The following is a description of a gene set: Human Gene Set: GOBP_SIGNAL_COMPLEX_ASSEMBLY species: Homo sapiens The aggregation, arrangement and bonding together of a set of components to form a complex capable of relaying a signal within a cell., and this is the list of marker genes: CD3E, PXN, NCK2, MAPK8IP2, PTK2, NCK1, SRC, PTK2B